Given this list of marker genes TMEM185A, NONO, SEPTIN6, GPC3, MTCP1, FOXO4, here is a description of the gene set: Amplification hot spot 13: colocolized fragile sites and cancer genes in the Xq12-q28 region. DNA copy number amplifications activate oncogenes and are hallmarks of nearly all advanced tumors. Amplified genes represent attractive targets for therapy, diagnostics and prognostics. To investigate DNA amplifications in different neoplasms, we performed a bibliomics survey using 838 published chromosomal comparative genomic hybridization studies and collected amplification data at chromosome band resolution from more than 4500 cases. Amplification profiles were determined for 73 distinct neoplasms. Neoplasms were clustered according to the amplification profiles, and frequently amplified chromosomal loci (amplification hot spots) were identified using computational modeling. To investigate the site specificity and mechanisms of gene amplifications, colocalization of amplification hot spots, cancer genes, fragile sites, virus integration sites and gene size cohorts were tested in a statistical framework. Amplification-based clustering demonstrated that cancers with similar etiology, cell-of-origin or topographical location have a tendency to obtain convergent amplification profiles. The identified amplification hot spots were colocalized with the known fragile sites, cancer genes and virus integration sites, but global statistical significance could not be ascertained. Large genes were significantly overrepresented on the fragile sites and the reported amplification hot spots. These findings indicate that amplifications are selected in the cancer tissue environment according to the qualitative traits and localization of cancer genes. Human Gene Set: MYLLYKANGAS_AMPLIFICATION_HOT_SPOT_13 species: Homo sapiens from publication Myllykangas S, Himberg J, Böhling T, Nagy B, Hollmén J, Knuutila S (PMID 16751803)